The following is a description of a gene set: species: Homo sapiens Subpopulations of human fetal thymocyte and circulating naïve T cells were obtained through FACS sorting, including CD3-CD4+CD8- intrathymic T progenitor cells (ITTP), CD3intCD4+CD8+ \double positive\ thymocytes (DP), CD3highCD4+CD8- \single positive\ thymocytes (SP4), CD3+CD4+CD8-CD45RA+CD62L+ naive T cells from cord blood (CB4+), and CD3+CD4+CD8-CD45RA+CD62L+ naive T cells from adult blood (AB4+). Human Gene Set: GSE1460_CORD_VS_ADULT_BLOOD_NAIVE_CD4_TCELL_DN from publication Lee MS, Hanspers K, Barker CS, Korn AP, McCune JM (PMID 15210650) Genes down-regulated in CD4 T cells from cord blood versus those from adult blood., and this is the list of marker genes: CRYBG1, GRAMD2B, PAF1, UGP2, APOC4, MARCHF6 (NCBI Gene Id 10299), FN3KRP, TOR1B, MAL, DELE1, ARHGAP25, TIAL1, TMEM230, ATP6V1B2, SCFD1, ST3GAL5, SF1, EZR, PURA, METAP2, AGL, DHRS7, AP3M2, RBM34, PPOX, ZNF263, ATP5F1A, PABPC4, GGPS1, ACAT1, DDX50, GOT1 (glutamic-oxaloacetic transaminase 1), SQSTM1, BCL2A1, HSPA8, ATP8A2 (ATPase phospholipid transporting 8A2), PSMC5, SH2D3A, SMARCE1, GORASP2, SYNE3, PLP2, GNRH1 (gonadotropin releasing hormone 1), POU3F2, PCBP1, DRG1 (NCBI Gene Id 4733), SVIL, USP1, NUDT9, SF3B1, GABPA, BFAR, ZNF331, MICU1, ZNF337, CRNKL1, PPP6R2, SORCS3, EEF1B2, ACTR3B, ZNF506, ITFG2, SEPHS2, PSIP1, ZBTB14, HNRNPD, ASNS, SYPL1, SERPINB6, ENO2 (enolase 2), PSMB9, MRFAP1L1, FGF9, HEXA, APMAP, RPL35A, PPP4R3A, LAMP1, MICA, SEC11A, HARS1, SF3A1 (splicing factor 3a subunit 1), GMPR2, SLC25A3, SKA1, PSMC2 (NCBI Gene Id 5701), SUPT7L, NDUFB5, NPEPL1, C3orf18, GALNS, SGCB, NISCH, TSN, CUZD1, LITAF, ERGIC2, LCP1, IGBP1, THAP11, CD6, SHOC2, YIPF1, ARFGAP2, RO60, GUSB, SERINC1, ASNSD1, DDX5, USP27X, UBE4B, ELOC, MSL3, RNF34, VAMP3, CLSTN1, PPIP5K1, APH1B, MBD1, ZNF35, MFSD5, CLK2 (CDC like kinase 2), FASTKD5, RFC1, RNF8, CDC14B, TASP1, SRP9, RBMXL2, PPCS, APOL3, NHERF1, CTSV, SAMHD1, REEP5, ADH5 (NCBI Gene Id 2223), CD48, ERCC8, ACSL5, SLC36A1, WDR1, ACACB, RPP14, FUS, AP3D1, JAM3, RABEPK, RBM7, GABARAP (GABA type A receptor-associated protein), ZNF12, PRKCA, ZNF227, HABP4, INTS14, PSMD6, PSMG1, TM7SF3, SS18L2, SP2, MTIF2, ITM2B, EEF1A1, HNRNPA1, GMFB, CNBP, MAP1LC3B, EIF3H, HNRNPF, UBQLN2, ADORA1, CDC42EP3, RASSF2, KIFBP, CXCR4, PNMA1, TMEM62, TPT1, GPD1L, PIK3C3, SRPRB, GSTT1 (NCBI Gene Id 2952), DNTTIP2, CPQ, NPLOC4, MAPK14, USP9X, CUL1, MRPS22, TARDBP, JADE2 (jade family PHD finger 2), INPP1, EPRS1, ZNF23, APOL2 (NCBI Gene Id 23780), GORASP1, SUMO3, DAD1 (NCBI Gene Id 1603), TEX261, CBX7